Given this list of marker genes Gm24968, Dexi, Mpv17l, Nlrc3, Rsl1d1, Gm10247, 1700037C18Rik, Gm3890, Pmm2, Tnp2, Gm6305, Glyr1, Gm35974, Gm25805, Gm7541, Dnaaf8, Mrtfb, Gm15950, Cpped1 (NCBI Gene Id 223978), Ifitm7, Trap1, Sec14l5, Gm6142, Gm15807, Gm6327, Zfp263, Gspt1, Gm18722, Naa60, Pphln1-ps1, Zfp597, Zc3h7a (NCBI Gene Id 223973), AU021092, Mgrn1, Nubp1, Mettl22, Ubald1, Gm23116, Gm30371, 1700003L19Rik, Gm19571, Gm4279 (NCBI Gene Id 100045394), Gm7638, Tekt5, Gm6332, Mir484, Rbfox1, Gm24667, 4833415N18Rik, Gm5766, Gm15538, Coro7, Snai2, Or1f21-ps1, Gm15806, Nudt16l1, Gm33696, Gm53058, Prm2, Gm24145, Shisa9, Mir193b, Gm6031, Gm15897, Prm1, Tmem114, Gm9961, Anks3, Vasn, Gm15808, Smim22, Nde1, Txndc11, Gm15558, Gm10832, Dnase1, Gm30567, Or1f20-ps1, Tfap4, Litaf, Gm7731, Gm3919, Tdgf1-ps1, Mefv, Clec16a, Gm22598, Bfar, A930007A09Rik (NCBI Gene Id 442828), A630010A05Rik, Clxn, Eef2kmt, Cep20, Emp2, Tnfrsf17, Socs1, Nagpa, Gm26159, Gm21859, Gm24579, Grin2a, 4930414F18Rik, Tmem186, Carhsp1, Gm38619, Pdxdc1, Pla2g10, Rrn3, Ppl, Litafd, Gm15537, Septin12 (NCBI Gene Id 75648), Mir6364, Mir6365, Gm15879, Gm41409, Snn, Bmerb1, Mir1945, Gm1600, 1700123O21Rik, Cdip1, Mir365-1, Marf1, Myh11, Ubn1, Nmral1, 1700016D08Rik, Gm4116, Rmi2, Tvp23a, Or2c1, Or1f19, Hapstr1, Gm4111, Usp7, 2310015D24Rik, Atf7ip2, Gm16861, Abcc1, Cluap1, Prm3, Abat, Gm23483, Snx29, Alg1, Ciita, Rpl39l, Gm46563, Gm25276, Hmox2, Ntan1, C87114, 4930509G22Rik, 4930562C15Rik, Zfp174, Gm5404 (NCBI Gene Id 385748), Gm1758, Rogdi, Crebbp (NCBI Gene Id 547230), Pla2g10os, Dnaja3, Gm10343, Gm3749, Pam16, Gm15539, Ercc4, Parn, Srl, Gm18724, Glis2, Gm7572, Gm15738, 2610020C07Rik, Gm15983, Slx4, Adcy9, Gm23706, here is a description of the gene set: Mouse Gene Set: chr16A1 species: Mus musculus